The following is a description of a gene set: studied in species Mus musculus Human Gene Set: RAO_BOUND_BY_SALL4 from publication Rao S, Zhen S, Roumiantsev S, McDonald LT, Yuan GC, Orkin SH (PMID 20837710) Murine embryonic stem (ES) cells are defined by continuous self-renewal and pluripotency. A diverse repertoire of protein isoforms arising from alternative splicing is expressed in ES cells without defined biological roles. Sall4, a transcription factor essential for pluripotency, exists as two isoforms (Sall4a and Sall4b). Both isoforms can form homodimers and a heterodimer with each other, and each can interact with Nanog. By genomewide location analysis, we determined that Sall4a and Sall4b have overlapping, but not identical binding sites within the ES cell genome. In addition, Sall4b, but not Sall4a, binds preferentially to highly expressed loci in ES cells. Sall4a and Sall4b binding sites are distinguished by both epigenetic marks at target loci and their clustering with binding sites of other pluripotency factors. When ES cells expressing a single isoform of Sall4 are generated, Sall4b alone could maintain the pluripotent state, although it could not completely suppress all differentiation markers. Sall4a and Sall4b collaborate in maintenance of the pluripotent state but play distinct roles. Our work is novel in establishing such isoform-specific differences in ES cells. Loci bound by both isoforms (a and b) of SALL4 in ES cells (embryonic stem)., and this is the list of marker genes: GJA1, XRN2, ADAM5, INSIG2, SLCO5A1, COL4A2, CHD7, JAM2, RPTOR, EOMES, INSYN2B (inhibitory synaptic factor family member 2B), MATR3, SYNCRIP, ZFP36L1, ZNF608, UHRF2, TP53BP1, PGAP6, TRIM2, TMEM220, EPC2, SLC5A1, MYOT, HSD17B11, RHOB, SSBP3, CWF19L2, NOLC1, GPM6A, BEND3, COBL, NPEPPS, TMEM64, SFTPD, OGT, TTC39B, SLC25A40, IDH1, BCAT1, FRYL, CST3, SLC39A14, TRIML1, FGD4, STAMBPL1, FN1, CD24, MTMR12, H2BC13, PHC1, OR5W2, ZNF585B, ZWINT, AARD, PARP6, SULF2, UBB, TCL1A, SLC25A1, PRSS48, MYCN, MOB4, TBX20, ABHD17B, ALG11, LYRM1 (LYR motif containing 1), TM2D2, TFAP2C, JARID2, ZCCHC7, SNTB2, PLEKHG5, UPP1, GJB3, MACO1, WEE1, FGF4, DYRK3, CPSF4L, TMEFF1, CFH, EPHX2, NR0B1, GTF3C6, ZC3HAV1, CACYBP, GNA13, ABT1, ARNT, MSANTD2, UBR5, H2AC8, SLCO4C1, MBTPS2, SLC38A2, KLF2, DNMT3A, FBXO36, TFCP2L1 (transcription factor CP2 like 1), FAM91A1, CYB5R1, MAP4K4, IRF2BPL, ZNF704, ZFP42 (ZFP42 zinc finger protein), OTX2, LMBRD2 (NCBI Gene Id 92255), REEP3, F2RL1 (NCBI Gene Id 7901), ZNF148, MAPK1IP1L, KCMF1, MAP10, GTF3C3, C2orf88, CIDEA, ZNF532, SPRED1, CEP112, CCDC141, NPTX2, CMKLR2, TMPRSS11D, HNRNPA2B1, ZDHHC14, PRDX6, TP53, STK38, SOX2, FGFR2 (fibroblast growth factor receptor 2), SLC44A1, SPRY2, SF3B4, PDGFC, REST, GRSF1, CASQ2, NEFL, LDB1, ASNS, ZSCAN10, TPD52, STMN1, MIB2, KDM2B, SPIC, DDAH1, TLK1, PDPK1, DENND2C, ETFRF1, FGFR1, AEBP2, RNF13, NKX2-2, PDHB (pyruvate dehydrogenase E1 subunit beta), GCNT2, ARHGEF18, ANP32A, KLHL34, FGFBP1, PDE1A (phosphodiesterase 1A), MAP1B, SEC16A, DKK1, YWHAG, AURKB, SERBP1, RYBP, MGAT4C, CCN2, ITGA1, B4GALT6, ZFP57, SUSD6, GNPNAT1, WHAMM, PRDM14, NANOG, FLRT3, PTGFRN, FBXO15, RGS20, KLHL5, MAX, PYROXD1, RAX, TRIM25, UBL3, SMG7, TXLNG, ZIC5, ADIPOR2, IL6ST (NCBI Gene Id 3572), EXOSC7, MZF1, C9orf152, VEGFC, SRSF11, CCDC38, GCM1, DUSP6, ARRDC3, ZNF280C, WTAP, HEXIM1, TRIM34, EYA1, USP48, H2BC3, NBR1, AKAP12, LIPH, IFITM1, HEXB, DGKH, PLIN2, H3C14, KIFC3, ZNF182, TSPAN15, ETV1, LPAR6, RAB38, CHD2, LRPAP1 (LDL receptor related protein associated protein 1), SEMA4B, ATG14